Given this list of marker genes MATCAP1, SLIT2, RECQL4, IRAK2, MKI67, TET2, SH3BP2, DCLRE1A, NDC80, TIMP4, PIH1D1, PGRMC1, AOPEP, CIT, ILDR1, LAMTOR3, LHX2, ERP44, TMBIM1, GEM, MASTL, ZNF593, PTPRK, ARF5, RCN1, TMPRSS13, CD79B, EEIG1, NAA10, POGK, TMEM14C, CHAF1B, GPSM2, HSD11B1, DHX32, SPATA16, DMRTA2, AARS2, IFITM2, E2F8, EHD1, UNC13D, TBX21, ITGA1, SNX11, SGCB, SGO1, PPP3CA, HMGB2, SLC39A14, DNAJC15, SLC30A4, MIP, INCENP, DDR1, SPAG5, SUCNR1, EXOC5, AARSD1, TSPAN4, LAIR1, KCNE2, CGRRF1, CCL5, HOPX, FAM124B, TSC22D3, NPB, HES3, IL2RA, SIAH1, FAM185A, RALA, DDX39A, ITGA2, PRUNE2, MCM3, TRAPPC8, GZMA, PDILT, RUNX2, FBXL15, FBXO27, TMOD3, FEN1, GPR179, STAC3, RIOK1, STRC, MINDY3, CRYBA4, KCNK6 (potassium two pore domain channel subfamily K member 6), SV2C, CYB561D2, ARL5A, KIF14, PUM3, RAP1GAP2, NEB, NCF1, WDR47, TXN, PPP1R18, COL16A1, MATN2, CITED1, FCER1G, SLC35B1, RAD18, TXNDC5, CCNA2, CRYBG1, HPGD, DPYSL2, FRMD6, STIL, KLRC1, CDKN1A, FAP (fibroblast activation protein alpha), PLEKHF1, COIL, HSPA1B, HK2, BARD1, POLA1, SIKE1, COLGALT2, TIPRL, F2RL3, SPSB3, MED21, ZSCAN20, VAX2, TMEM81, KLRD1, RNASEH2C, TEX30, OSBPL3, ULBP1, VIM, ARL4C, WDR37 (WD repeat domain 37), GIMAP7, OVOL2, ADAP1, NDUFA4L2, RIOX2, GAS7 (NCBI Gene Id 8522), FOXN3, PBDC1, SATL1, S100A6, ARL5B, ERRFI1, SOWAHC, NPLOC4, HID1, ALPI, HIC1, VPS36, CYTH4 (cytohesin 4), NEURL1B, B3GAT3, PSMD8, FCGR2B, TBKBP1, CDC14B, CHD7, JPT2, C19orf53, YRDC, GLRX, SOCS2, FANCD2, SYK, S1PR5, ARID3B, CD86, SNX9 (sorting nexin 9), TYROBP, RACGAP1, EXOSC9, KIAA0040, ERN2, PIK3AP1, CALB1, TRPC1, GBP7, HAUS6 (HAUS augmin like complex subunit 6), ST3GAL6 (ST3 beta-galactoside alpha-2,3-sialyltransferase 6), NCK2, SLC38A2, OGN, CENPE, TMEM86B, PPP1R1B, LFNG, CENPA, MTMR1, FASLG, here is a description of the gene set: Discrimination between self vs. non-self and adequate response to infection and tissue damage are fundamental functions of the immune system. The rapid and global spread of known and emerging viruses is a testament that the timely detection of viral pathogens that reproduce within host cells, presents a formidable challenge to the immune system. To gain access to a proper reproductive niche, many pathogens travel via the host vasculature and therefore become exposed to humoral factors of the innate immune system. Although a cascade of coagulation factors plays a fundamental role in host defense for “living fossils” such as horseshoe crabs (Xiphosurida spp), the role of the coagulation system in activation of innate responses to pathogens in higher organisms remains unclear. When human type C adenovirus (HAdv) enters the circulation, 240 copies of coagulation factor X (FX) bind to the virus particle with picomolar affinity. Here, using molecular dynamics flexible fitting (MDFF) and high resolution cryo-electron microscopy (cryo-EM), we defined the interface between the HAdv5 hexon protein and FX at pseudo-atomic level. Based on this structural data, we introduced a single amino acid substitution, T424A, in the hexon that completely abrogated FX interaction with the virus. In vivo genome-wide transcriptional profiling revealed that FX-binding-ablated virus failed to activate a distinct network of the early response genes, whose expression depends on transcription factor NFKB1. Deconvolution of the signaling network responsible for early gene activation showed that the FX-HAdv complex triggers MyD88/TRIF/TRAF6 signaling upon activation of toll-like receptor 4 (TLR4) that serves as a principal sensor of FX-virus complex in vivo. Our study implicates host factor “decoration” of the virus as a mechanism to trigger innate immune sensor that respond to a misplacement of coagulation FX from the blood into intracellular macrophage compartments upon virus entry into the cell. Our results further the mounting evidence of evolutionary conservation between the coagulation system and innate immunity. Human Gene Set: GSE36078_UNTREATED_VS_AD5_T425A_HEXON_INF_MOUSE_LUNG_DC_DN Genes down-regulated in Lung dendritic cell from untreated wildtype mice versus Lung dendritic cell from Ad5 T424A hexon infection wildtype mice. species: Homo sapiens from publication Doronin K, Flatt JW, Di Paolo NC, Khare R, Kalyuzhniy O, Acchione M, Sumida JP, Ohto U, Shimizu T, Akashi-Takamura S, Miyake K, MacDonald JW, Bammler TK, Beyer RP, Farin FM, Stewart PL, Shayakhmetov DM (PMID 23019612)